Given this list of marker genes H2bc1, Htra1, Rps6ka2, Ms4a6b, Plin2, Tyrobp, Stab1, C3ar1, Mmp12, Cd300c2 (CD300C molecule 2), Ifi207, Saraf, Cp, Tfpi, Ccl3, Fermt3, Igfbp3, Rnf19b, Car3, Mllt11, Mccc1, Cfp, Timp3, H2bc4, Rhob, Ubfd1, Plscr2, Trpv2, Csf1r, Clec4d, Mmp13, Igfbp2, Upk3b, Rabac1, Ndrg4, Renbp, Mien1, Ccl2, H13 (NCBI Gene Id 99254), Rbp1, Fbxo9, Skap2, Ctla2a, Syngr1, Mest, Ngf, Ccn4, Gabrb1, Lcp2, Gng11, Fabp7, Lgals9, Cd14, Actg2, Uchl1, Ptprc, Cfhr4, Ivl, Vav1, Lmo2, Pla2g7, Atp6v0b, Zdhhc14, Tec, Npr3, Adam8, Shroom3, Ninj1, Prl2c2, Dctn6, Slc22a23 (solute carrier family 22, member 23), Pon2, Colgalt1, Hmox1, Arl5a, Tpd52l1, Spi1, Rb1, C1qb (NCBI Gene Id 12260), Gabarapl1, Gsta4, C1qc, Ifi30 (interferon gamma inducible protein 30), Kdm5b, Cd59a, Msrb1, Srgn, C1qa, Acta1, Krt18, Prdx2, Egfr, Ackr4, Hpgd, Rnf149, Dcn, Parm1, Slco3a1, Msr1, Apoe (apolipoprotein E), Rasl11b, Ccl9, Enah, Crct1, Prrc1, Slc1a6, Irf5, Il6, Cadm1, Edn1, Tph1, Sqstm1, Gjb3, Tgfb2, Tceal9, Plac8, Septin11, Nupr1, Pld3, Lilrb4b, Slfn2, Ube2a, Cd53, Pstpip1, Ctss, here is a description of the gene set: from publication Markey MP, Bergseid J, Bosco EE, Stengel K, Xu H, Mayhew CN, Schwemberger SJ, Braden WA, Jiang Y, Babcock GF, Jegga AG, Aronow BJ, Reed MF, Wang JY, Knudsen ES (PMID 17452985) studied in species Mus musculus Mouse Gene Set: MARKEY_RB1_CHRONIC_LOF_DN Genes down-regulated in MEF cells (embryonic fibroblasts) isolated from RB1 knockout mice: chronic loss of function (LOF) of RB1. Functional inactivation of the retinoblastoma tumor suppressor gene product (RB) is a common event in human cancers. Classically, RB functions to constrain cellular proliferation, and loss of RB is proposed to facilitate the hyperplastic proliferation associated with tumorigenesis. To understand the repertoire of regulatory processes governed by RB, two models of RB loss were utilized to perform microarray analysis. In murine embryonic fibroblasts harboring germline loss of RB, there was a striking deregulation of gene expression, wherein distinct biological pathways were altered. Specifically, genes involved in cell cycle control and classically associated with E2F-dependent gene regulation were upregulated via RB loss. In contrast, a program of gene expression associated with immune function and response to pathogens was significantly downregulated with the loss of RB. To determine the specific influence of RB loss during a defined period and without the possibility of developmental compensation as occurs in embryonic fibroblasts, a second system was employed wherein Rb was acutely knocked out in adult fibroblasts. This model confirmed the distinct regulation of cell cycle and immune modulatory genes through RB loss. Analyses of cis-elements supported the hypothesis that the majority of those genes upregulated with RB loss are regulated via the E2F family of transcription factors. In contrast, those genes whose expression was reduced with the loss of RB harbored different promoter elements. Consistent with these analyses, we found that disruption of E2F-binding function of RB was associated with the upregulation of gene expression. In contrast, cells harboring an RB mutant protein (RB-750F) that retains E2F-binding activity, but is specifically deficient in the association with LXCXE-containing proteins, failed to upregulate these same target genes. However, downregulation of genes involved in immune function was readily observed with disruption of the LXCXE-binding function of RB. Thus, these studies demonstrate that RB plays a significant role in both the positive and negative regulations of transcriptional programs and indicate that loss of RB has distinct biological effects related to both cell cycle control and immune function.